Given this list of marker genes ENPP2, APEX1, ENPP1, FAN1, ENPP3, here is a description of the gene set: Catalysis of the sequential hydrolytic removal of 5'-nucleotides from the 3'-hydroxy termini of 3'-hydroxy-terminated oligonucleotides. Human Gene Set: GOMF_PHOSPHODIESTERASE_I_ACTIVITY studied in species Homo sapiens